The following is a description of a gene set: Human Gene Set: REACTOME_TCR_SIGNALING TCR signaling species: Homo sapiens, and this is the list of marker genes: SEM1, PIK3R1, LAT, UBA52, TRAT1 (NCBI Gene Id 51488), PDPK1, PLCG1, UBE2D2, HLA-DQB1, TAB2, PSMA4, HLA-DRB3, TRAV8-4, CD3D, PSMD13, PSMB3, PSMC5, PTEN, ITK, FYB1, CSK, NCK1, CUL1, HLA-DRB5, EVL (Enah/Vasp-like), PSMA2, PSMD8, PAK1, CARD11, HLA-DQA2, PLCG2, CD3G, IKBKG, PSMA6, MALT1, TRBV12-3, PSMB1, BCL10, PSMC1, PSMD14, TRAV19, PSMA7, NFKBIA, HLA-DQA1, CD101, HLA-DPB1, RPS27A, HLA-DRB4, LCK, PSMD2, NFKB1, RIPK2 (NCBI Gene Id 8767), PSMC2, PSMC3, PSMA5, PSMA3, UBE2D1, ZAP70, RELA, PSMD11, PSMD6, PAK2, CD247, BTRC, PSMB5, PAK3, LCP2, ADRM1, UBB, TRAF6, INPP5D, HLA-DPA1, ENAH, PSMD1, PTPRC, UBC, WAS, GRAP2, MAP3K7, PSMB6, PSMC6, FBXW11, HLA-DQB2, CD3E, SKP1, IKBKB, UBE2N, PSMD7, PSMB7, PIK3CB, CHUK, PSMA1, HLA-DRA, PIK3CA, PSMB2, TRAV29DV5, UBE2V1, CDC34, PTPN22, PTPRJ, PRKCQ, PSMD3, TRBV7-9, PSMC4, VASP, HLA-DRB1, PSMB4, PIK3R2, PSMD12, PAG1, CD4